The following is a description of a gene set: The goal of the study was to identify the effects of TGF-beta on primary human macrophages maturated under different conditions. Genes down-regulated in macrophages differentiated in the presence of IL4 for 5 days versus those subsequently treated with TGFB1 for 24h. Human Gene Set: GSE7568_IL4_VS_IL4_AND_TGFB_TREATED_MACROPHAGE_24H_DN studied in species Homo sapiens from publication Gratchev A, Kzhyshkowska J, Kannookadan S, Ochsenreiter M, Popova A, Yu X, Mamidi S, Stonehouse-Usselmann E, Muller-Molinet I, Gooi L, Goerdt S (PMID 18453574), and this is the list of marker genes: HOXA5, GTF2F2, FUT7, DNAJC2, MRPL23, GFPT1 (NCBI Gene Id 2673), CRYZ, FOXK2, BANF1, QTRT1 (NCBI Gene Id 81890), GFM1, FPGS, ST14, MGAT4A, TGFBR3, RABGGTB, ATP13A3, CDC26 (NCBI Gene Id 246184), HMGCS1, FAM98A, EIF4G1, PHAX, NOMO1, NOL8 (NCBI Gene Id 55035), PFDN6, AGPAT3, ALG3, USP36, KRTCAP2 (keratinocyte associated protein 2), CDV3, GSR, HADH, HSF1, SSR1, CCND2, POLR1A, MRPL18, SCARB1, PSAT1, THOC3, UTP20, RCL1, KAT2A, HASPIN, GZMA, ATXN7L2, MRPL36, DDX39A, NMD3, PLK3, RWDD4, FUBP1, PHF5A, CCND3, MRPS15, ARFIP2, CXCR4, KLHDC4, ERLIN1, AKAP1, ROGDI, AKAP8, PALS2, ZC3H18, RARS2, ZWINT, DTD1, BAG2, FAM222B, SRP68, CALR, SLC39A6, SLC30A5, TPST1, DENR, RBM28, PRMT7, NOC4L, ALKBH5, SMYD2, MRPS7, EIF6, RWDD1, SREK1IP1, ACSL1, ALAD, MLH1, DPAGT1, NDUFS5, COQ5, HSF2, RANGAP1, NEFH (NCBI Gene Id 4744), GET1, TXNL4A, CUTA, ADI1, TNFRSF8, NAA20, HPDL, PCNP, DPY30, SNUPN, LIPT2, ACACA, MFSD2A, ZBTB7B, DNAJC24, HUS1, KPNA3, TTC27, UHRF1, ATPAF2, TUBB2A, RPL36, DCAF1, HSD17B12, MRPS31, PREP, ACOT7, PSMB3, PRELID3B, ARL6IP4, MCM10, INSIG1, NUDCD1, POLR2C, TADA2A, NOL11, AARSD1, POLR3D, IPO11, NAF1 (NCBI Gene Id 92345), DAZAP1, PDCD2L, AHCTF1, CD81, AKT1, RARS1, GCSH, GUK1 (NCBI Gene Id 2987), TSEN2, MAPK1IP1L, BCLAF1, AAAS, TRIP13, MRPS12, NOP10, NDUFAF1, GCNT1, SUCLG2, MICAL3, RANBP1, PSME3, AMD1, RNU12, EIF1, FARSA, BOP1, C1QBP, EFTUD2, MRPL49, TCERG1, MRPL50, HSPA4, MCPH1, NUP43, SLC16A6, TMEM97, EXOSC1, IMPDH2, BPIFB3, PIM1, FASTKD3, TMEM11, NIFK, RAD51AP1, POLR2K, CANX, PLP2, TFDP1, TXN2, MRPL17, INTS7, CCR4, PSMC4, RPL30, MAOA